Given this list of marker genes Hecw2, Bltp3b, Zfta, Gpat3 (NCBI Gene Id 71048), Fbxo42, Cyth3, Cadm2, Zfp704, Lrrtm2, Cdh2, Bmp2, Arl6ip6, Lpar4, Frrs1l, Utp23, 2300009A05Rik, Col4a3, Ppp2r5e, Gm904, Smc6, Inpp5f, Brox, Phex, Cyb561d1, Atp11a, Tut4, Scara5, Col19a1, Msx2, Ppp3ca, Nedd9, Scml4, Ccn4, Ccpg1, Ndufaf5, Six4 (sine oculis-related homeobox 4), Vsnl1, Angpt2, Map1b, Bdnf, Slc25a11, Kcnd3, Slfn4, Fut9, Runx1, Rora, Kcnd2, Uqcrc2, Traf3, Matr3, Avl9, Larp1, Zbtb18, Osbpl3, Lrrc55, Nme8, Mtcl2, Baz2a, Ank2, Fbxo45 (NCBI Gene Id 75407), Rimklb, Bnc1, D930020B18Rik, Ccdc92b, Sorcs1, Npr2, Tent5d, Rspo3, Chrna5, Atp6v1b1, Slc5a3, Fdx1, Tgfb2, Nxph1, Tifa, Nat8l, Fbxl22, Meioc, Psat1, Samd4b, Zfp24, Colec11, Pkp2, Etv1, Trim67, Clptm1, Zfp503, Urb2, Emilin3, Bloc1s2, Ccnk, Dse, Tceal7 (transcription elongation factor A (SII)-like 7), Ndst3, Dzank1, Ptprj, Tmem72, Lpp, Atp6v1g3, Enah, Selenot, Dpp8, Pogz, Eloc, Dcx, Chmp4c (NCBI Gene Id 74324), Vim, Zfp36l1, Serf2, Atad5, Dnm1l, Aspn, Ergic2, Atxn1, Tacr1, Zfand5, Prelp, Cntd1, Prrg1, Btbd2, Purb, Dcaf5, Tdrp, Ncam2, Ube3a, Naaladl2, Faxc, Tom1l1, Nt5c2, Cep57l1, Tbx4, Cul3 (cullin 3), Ube2n, Acvr2a, Ankrd28, Dpyd, Mylk4, Utp6, Map4k5, Zmym2, Gnaq, Serpine2, Smg1, Zmynd15, Lhx6, Cadm1, Epha4, Rbms3, Sgms1, Cstf3, Map7d3, Col1a1, Ube2q1, Gabrb2, Tfap2b, Nasp, Ss18l1, Lrp8, Srrm4, Nrxn2, Gpr141, Kpnb1, Vti1a, Bcan, Phip, Lpar1, Hnf4g, Wdr33, Cry1, Eml1, Aff4, Zbtb6 (zinc finger and BTB domain containing 6), Adam22, Cyp2c50, Hnrnpul2, Cd93, Calu, Atg12, Fndc5, Tcea1, Otulinl, Ubp1 (NCBI Gene Id 22221, upstream binding protein 1), Samd11, Spink13, Nipal4, Dag1, Tceal1, Kcnmb2, Plekhg1, Npy2r, Nck2, Cdon, Kir3dl1, here is a description of the gene set: Genes predicted to be targets of miRBase v22 microRNA mmu_miR_684 in miRDB v6.0 with MirTarget v4 prediction scores > 80 (high confidence targets). Mouse Gene Set: MIR_684 studied in species Mus musculus from publication Chen Y, Wang X (PMID 31504780)